Given this list of marker genes TMLHE, VPS29, RACGAP1, EMC7, CCDC92, SLC3A2, UQCC2, VPS39 (NCBI Gene Id 23339), GLRA3, ARL6IP4, CBLC, FOS, TLL2, SEPHS2, CRELD1, RPL9, H1-2, RPAP1, MESD, TSPAN3, CDX4, RHOT2, COPE, ACSS2, GOT2, CDK18, EVI2B, PNLIPRP1, BLVRA, NPM1, NUP107, VAMP1, DDHD2, CCDC22, NAA38, ODR4, DAPK1, FAM50A, WDR74, PTDSS1, CCNH, ABHD8, DPF3, EMC2, SRM, MIX23, SPC25, TFAP4, PDE8A, PDF, NDUFC2, SRSF6, ACSM2A, LIPT2, ATP13A2, AIP, SLC37A1 (NCBI Gene Id 54020), YAE1 (NCBI Gene Id 57002), CCL2, UHRF1 (NCBI Gene Id 96185), POFUT2, TIMM9, RRAS, RIOX2, ASRGL1, SLC5A3, SLAMF8, KCTD12, FKBP10, NDUFA7, POLR3G, BCL2L11 (NCBI Gene Id 150819), ACTN4, NTPCR, FPGS, RPS8, FAS, NME6, RAP2A, CASR, UBE2C (ubiquitin conjugating enzyme E2 C), SEC11A, EIF3L, OR2S2, HTATIP2, AKAP3, C3orf70, MRPL40, CPSF1, AGBL3, STX7, POLR1H (NCBI Gene Id 30834), PTCD2, EBI3, ANKRD40, OTULINL, SGK1, NAB2, TARS1, RMC1, LTC4S, C1QBP, KRT85, WAS, SLC34A1, AKR1E2, HNRNPDL, HMBS, CTDNEP1, EVL, VPS26A, MKNK1, PSMG1 (NCBI Gene Id 8624), BHLHE22, TUBA4A, RIMKLB, MMP7, RAF1, RNF149, DEPDC7, HDHD2, MYO7A, THOC1, SASH1, TMEM38B (NCBI Gene Id 55151), ADGRE5, MCOLN2, PMVK, NOL11, TUBA8, S100A8, RHBDL3, GSS, INPP5D, MYADM, HFE, CCT2, IFNB1, C12orf43, ZZZ3, ABCG2, RCC2, CSF1R, TMEM158, PAK1, ATAD3A, LAS1L, NFE2L2, PEG3, TFEB, ARIH2, NKIRAS1, MARCO, LAMA3, ZXDC, ABHD4, ITGBL1, LAMTOR3, PPARG, ZNF707, MBNL1, MCM7 (minichromosome maintenance complex component 7), TUBB3, ADAM18, ELOVL1, CCR1, BTF3L4, DOLPP1, PACS1, DUSP6, BYSL, MAL2, ZYX, LAD1, GNPDA1, NOP14, SLC38A3, FLAD1, INTS7, FERRY3, GNGT1, ATP6V1C1, UFC1, APEX1, PLIN3, TRMT2A, PGRMC2, CEP20, CNTLN, MAP4K2, WASHC2A (WASH complex subunit 2A), ASB4, SRD5A3, HEXB, MLLT11, ZCCHC17, CD84, RORB, CCT8, MGLL, here is a description of the gene set: Human Gene Set: GSE17721_LPS_VS_CPG_6H_BMDC_DN from publication Amit I, Garber M, Chevrier N, Leite AP, Donner Y, Eisenhaure T, Guttman M, Grenier JK, Li W, Zuk O, Schubert LA, Birditt B, Shay T, Goren A, Zhang X, Smith Z, Deering R, McDonald RC, Cabili M, Bernstein BE, Rinn JL, Meissner A, Root DE, Hacohen N, Regev A (PMID 19729616) species: Homo sapiens mouse primary BMDCs were stimulated with tlr ligands and gene expression changes were profiled on Affymetrix arrays Genes down-regulated in comparison of dendritic cells (DC) stimulated with LPS (TLR4 agonist) at 6 h versus DC cells stimulated with CpG DNA (TLR9 agonist) at 6 h.